Given this list of marker genes DHX9, AGO1, AGO2, PRKRA, AGO3, DICER1, TARBP2, AGO4, here is a description of the gene set: A trimeric protein complex required for the formation of a mature RNA-induced silencing complex (RISC). In humans the complex is composed of the endonuclease Dicer (DICER1), TRBP (TARBP2) and the Argonaute protein Ago2 (EIF2C2/AGO2). Within the complex, Dicer and TRBP are required to process precursor miRNAs (pre-miRNAs) to mature miRNAs and then load them onto Ago2. Ago2 bound to the mature miRNA constitutes the minimal RISC and may subsequently dissociate from Dicer and TRBP. This complex has endoribonuclease activity. studied in species Homo sapiens Human Gene Set: GOCC_RISC_LOADING_COMPLEX